Given this list of marker genes Kit, Lyn, Stat5a, Il3 (interleukin 3), Rac2, Kitl, here is a description of the gene set: Any process that activates or increases the rate or extent of mast cell proliferation. Mouse Gene Set: GOBP_POSITIVE_REGULATION_OF_MAST_CELL_PROLIFERATION studied in species Mus musculus